The following is a description of a gene set: Human Gene Set: MIR602 from publication Chen Y, Wang X (PMID 31504780) studied in species Homo sapiens Genes predicted to be targets of miRBase v22 microRNA hsa-miR-602 in miRDB v6.0 with MirTarget v4 prediction scores > 80 (high confidence targets)., and this is the list of marker genes: DNAJC3, TENM4, MTF2, ORMDL1, NOG (NCBI Gene Id 9241), HTT, SPIRE1, ZNF396